Given this list of marker genes CDKN1B, PTGFR, EGR1, PRL, NPEPPS, CDK4, PRLR, CEBPB, here is a description of the gene set: Human Gene Set: MATZUK_LUTEAL_GENES Reproduction is required for the survival of all mammalian species, and thousands of essential 'sex' genes are conserved through evolution. Basic research helps to define these genes and the mechanisms responsible for the development, function and regulation of the male and female reproductive systems. However, many infertile couples continue to be labeled with the diagnosis of idiopathic infertility or given descriptive diagnoses that do not provide a cause for their defect. For other individuals with a known etiology, effective cures are lacking, although their infertility is often bypassed with assisted reproductive technologies (ART), some accompanied by safety or ethical concerns. Certainly, progress in the field of reproduction has been realized in the twenty-first century with advances in the understanding of the regulation of fertility, with the production of over 400 mutant mouse models with a reproductive phenotype and with the promise of regenerative gonadal stem cells. Indeed, the past six years have witnessed a virtual explosion in the identification of gene mutations or polymorphisms that cause or are linked to human infertility. Translation of these findings to the clinic remains slow, however, as do new methods to diagnose and treat infertile couples. Additionally, new approaches to contraception remain elusive. Nevertheless, the basic and clinical advances in the understanding of the molecular controls of reproduction are impressive and will ultimately improve patient care. from publication Matzuk MM, Lamb DJ (PMID 18989307) Luteal genes, based on mouse models with female fertility defects. studied in species Homo sapiens